Given this list of marker genes H2ac19, H3c6, Psmd12, Psmc4, Psmb5, Gata2, H3c7, Smarcd2, H3c10, H4c3, Trp73, Psmc1, H2bc1 (NCBI Gene Id 319177), Scmh1, Smarcb1, Gata1, Cbx6, Rps27a, Psma3, H2ac4, H2ac1 (H2A clustered histone 1), Psmd7 (NCBI Gene Id 17463), Csnk2b, H3c15, H3c8, Setd1a, H2ac10, Psmb6, Ring1, Ash2l, H2bc3, H2az2, H2bc13, Tcf3, Psmd1, H4c2, H4c8, Ep300, H2bc27, Gata3, Smarcc1, H2ac15, Ccnd1, H4c14, H2ac22 (NCBI Gene Id 319170), H2ac8, H4c18, H2ac23, Lmo2, Ccnh, Actl6b, Cbx4, Phc1, H4c11, H2ac11, Kmt2b, Psmb4, H4c1, H2bc9, Ubb, Pax5, H2bc15, Psmc5, Yap1, Smarca2, H2ac13, H4c17 (H4 clustered histone 17), Arid1a, Cbx8, H3c13, Psma6, H2bc8, H3c1, H3c2, Yaf2, H2bc12, Psma5, H4c12, Tal1, Sin3a, Foxp3, H2ac20, Psma7, H2ac6, Psmc3, H2bc11, H4c4, Serpinb13, Psma2, Smarcc2, H3c4, Ldb1, Bmi1, Psma1, Smarca4, H2ax, Psmd6, H2ac12, Zfpm1, H2ac7, Psmb7, Cbx2, H2ac24, Smarcd1, H2bc7, H4c9, Cbfb, H3c3, H3f3a, Elf1, Psma4, Esr1 (estrogen receptor 1 (alpha)), H2bc22, H4c6, Psmc6, Psmc2, H3c11, Psmd13, here is a description of the gene set: electronically inferred by orthology from the curated human pathway studied in species Mus musculus This event has been computationally inferred from an event that has been demonstrated in another species.<p>The inference is based on the homology mapping from PANTHER. Briefly, reactions for which all involved PhysicalEntities (in input, output and catalyst) have a mapped orthologue/paralogue (for complexes at least 75% of components must have a mapping) are inferred to the other species. Reactome Pathway: Transcriptional regulation by RUNX1 part of: Generic Transcription Pathway